The following is a description of a gene set: The presence of blood in the urine. Hematuria may be gross hematuria (visible to the naked eye) or microscopic hematuria (detected by dipstick or microscopic examination of the urine). Hematuria studied in species Homo sapiens Human Gene Set: HP_HEMATURIA, and this is the list of marker genes: SDHAF2, SLC2A9, LMX1B, HMOX1, CLDN19, HOGA1, NPHP3, FCGR2C, CUBN, LPIN2, ACSL4, MMACHC (NCBI Gene Id 25974), STAT3, PML, CTLA4, F5, PTPN22 (NCBI Gene Id 5779), PKD1, SDHC, TMEM127, DPH1, HBB, IL17RA, TBL1XR1, C4B, FAN1, APOA1, SPTBN1, COL4A5, WT1, TSC1, DNASE1, NUP133, PRDX1, SREBF1, ALG5, TNFSF4, IRF2BP2, DNASE1L3, TLR7, SLC5A1, TREX1, DNAJB11, TNIP1, CFI, SCARB2, KIF1B, IGHG1, MECP2, GANAB, YAP1, F9, FGA, IRF5, H19, SLC34A2, PRTN3, BANK1, PBX1, ETS1, KANK2, NF1, IL10, GPC3, INF2, MAX, ITGA2, MCFD2, HNF1B, FIP1L1, SLC22A12, TRAF3IP2, C4A, BLK, DLST, RET, SMARCAL1, STAT4, HLA-DPB1, NPM1, GP1BA, REST, ADAMTS13, IL17RC, PFKM, LARS2, LAMB2 (NCBI Gene Id 3913), NABP1, NOTCH2, IL17F, THBD, CR2, UMOD, F2, PKD2, LMNB2, CLDN16, FN1, SDHA (succinate dehydrogenase complex flavoprotein subunit A), HLA-DRB1, SDHD, ZBTB16, TRIP13, VHL (von Hippel-Lindau tumor suppressor), SPP1, GP1BB, GP9, FCGR2B, UBE2L3, HLA-DPA1, FH, FCGR3B, AGGF1, ITGA6, TSC2, COL6A1 (NCBI Gene Id 1291), NUMA1, GBA1, KIAA0319L, CLEC7A, KCNE5, CTNS, SLC37A4, LMAN1, NUP93, NOS1AP, COL4A3, IRAK1, SLC25A11, ITGAM, F8, SERPINF2, CD2AP, PAX2, P4HA2, SPRY2, JAZF1, CD46, CD81, GATA3, ITGB3, PRKAR1A, CFHR5, RARA, BICC1, SEC61A1, TNFAIP3, ITGB4, CD109, COL4A4, BRCA2, F10, CFH, HLA-B, UMPS, EPAS1 (NCBI Gene Id 2034, endothelial PAS domain protein 1), COL4A1, APRT, GLA, DIS3L2, SAT1, STIM1, COL4A6, AMMECR1, POU6F2, BCOR, SDHB, STAT5B, ACP5, IFT140, TRIM28, AGXT (alanine--glyoxylate aminotransferase), PIK3CA, MYO1E, C3, CLCN5, MDH2, ALG9, SLC7A7, ITGA2B, DNMT3A, NUP85, CFB, PDCD1, PXK, OCRL, GRHPR (glyoxylate and hydroxypyruvate reductase), HPRT1